Given this list of marker genes RAB15, ARAP3, SEMA6A, ATXN2L, RANBP10, PHAF1, LRRC75A, XBP1, DGKZ, STIP1, FAM53C (family with sequence similarity 53 member C), BCL2L1, ZNF827, GRAMD1A, CEMIP, KLF12, ITGA11, GIT1, NSD2, SMARCD2, CD44, DLEC1, SKIDA1, MCRS1, C22orf46P, ALDH1A2, SSBP3, BCAP29, SEPTIN6, SLC1A2, PDGFRB, ROM1, BNIPL, BTG2, ZMYND11, RASGRP4, YPEL1, KLF11, RREB1, ZFAND3, PLAGL2, HOXB5, CCDC88B, CAMKV (CaM kinase like vesicle associated), UBR7, ADGRL1, B3GAT3, JPH1, IQSEC2 (NCBI Gene Id 4382), GLCCI1, PHF2, VAMP1, LBX1, FOS, KCND1 (NCBI Gene Id 3750), CCDC120, CHRD, LRRC4, RARA, FAM131B, FAM133B, MAT2A, EHMT2, EMC3, PARVA, SP7 (Sp7 transcription factor), H1-0, VCP, ACOT7, TOMM34, PGAP2, UHRF2, MDGA2, JUNB, CAMK2G, GPD1, SBK1, ABCF1, DSCAM, OPCML (opioid binding protein/cell adhesion molecule like), NR1D1, SRSF1, DPH2, USP6, MRPS16, CACUL1, TWIST1, OVOL1, RUSF1, MBD6, GRK6, C16orf86, SND1-IT1, CHD4, RNF19A (NCBI Gene Id 81036), TBC1D2B, KCNH8, FBXL17, NSD3, KLF13, GLYR1, S100A8, UBAP1, PHF13, IER5L (immediate early response 5 like), IFFO1, DGKI, ZBTB47, PACSIN2 (protein kinase C and casein kinase substrate in neurons 2), FOSL1, KRT40, TMUB2, B4GALT3, GPRASP2, AMDHD2, PARP6, TXNL4B, SH2B3, TYSND1, EFNB1, LIMK2, SPRY3, TMEM191A, MFN1, KMT2A, PPP1R9B, SLC12A5, BNC2, MAP3K9, BRD2, NFASC, ABCA9, RNF121, SLC25A22, COMMD3, ARK2C, ZNF609 (NCBI Gene Id 23060), PSD3, TSPYL5, TRIM35 (tripartite motif containing 35), INTS11, EI24, SNX27, POGZ, MSTO1, RGS16, ACSL5, TEAD3, DNAJB5, SEC24C, DNAJB2, SMG1, MAP3K3, PPP1R3F, THRA, HERC4, PARD3B (NCBI Gene Id 65063), AP1S3, USP19, NAV1, TOR2A, SORT1, RNF44, here is a description of the gene set: Human Gene Set: GAGCTGG_MIR337 Genes having at least one occurence of the motif GAGCTGG in their 3' untranslated region. The motif represents putative target (that is, seed match) of human mature miRNA hsa-miR-337 (v7.1 miRBase). species: Homo sapiens